Given this list of marker genes NEXMIF, KCNMA1, SYNJ1, SZT2, KCNQ2, GABRA1, AKT3, PCDH19, ITPA, PDE2A, SLC12A5, SCN1A, SCN8A, KCNT1, PDSS2, NDUFA8, POLG, SON, NARS2, KCTD7, GNB1 (G protein subunit beta 1), CILK1, KCNC2, GABBR2, TBC1D20, ODC1, FGF12, BSCL2, STRADA, LMNB2, KIF11, TSC2, COQ2, SLC2A1, ASAH1, TBC1D24, AP3B2, TRAPPC2L, GRIN2A, ADORA2A, TBCK, RHOBTB2, ALDH5A1, GABRA5, GOSR2, KCNH5 (NCBI Gene Id 27133), COG8, SATB1, CTSD, SMARCAL1 (NCBI Gene Id 50485), EHMT1, SMARCA2, EEF1A2 (NCBI Gene Id 6669), DNM1L, FOXG1, PARS2, NHLRC1, GRIN2D, EPM2A, AGO1, CACNA2D1, CACNA1B (NCBI Gene Id 774), TRAK1, NFU1, CNKSR2, SCN1B, PUM1, ACTL6B, CDKN1A, CACNA1E, UNC93B1, CLTC, TSC1, DIS3L2, ARV1, ATP1A1, ALDH4A1, TRAF3, AMACR, PGM2L1, ATP6V0A2, GABRA2, ATP5PO, TEFM, KCNA2, TICAM1 (TIR domain containing adaptor molecule 1), NDUFA6, GABRB2, DHDDS, PPP3CA, PSAP, CDKN1B, FZR1, ATP1A2, TWNK, IQSEC1, ST3GAL5, SYNGAP1, DHCR24, VARS1, BRAT1, PACS2, PIGS (NCBI Gene Id 94005), CACNB4 (NCBI Gene Id 785), CLN6, BCL10, FBXO28, SLC1A2, GRIA4, JRK, KCNQ3, SVBP, COX10, TBK1, VAMP2, QARS1, GPAA1, ARX, CELF2, IFNG, FGF13, AARS1, CDKN2B, GABRD, STXBP1 (NCBI Gene Id 6812), ADGRV1, FIG4, ATP6V1A, GLYCTK, CLCN2, ATXN10, NECAP1, GRIA3, WDR4, SCN9A, YWHAG, CYFIP2, SLC32A1, FH (fumarate hydratase), RNU4ATAC, CRELD1, VPS51, MRM2, ATP1A3, SLC1A3, CACNA1A, PRRT2, GRM7, UBA5, ECE1, SCN3A, MECP2, TLR3, GRIN2B, CDK19, CCDC88A, SLC19A3, GET4, PRODH, KCNB1, PET100, RRM2B, DALRD3, AQP4, CARS2 (cysteinyl-tRNA synthetase 2, mitochondrial), CDKN2C (cyclin dependent kinase inhibitor 2C), PIGA, CAD, COQ8A, MICU1, DNM1, HNRNPU, CHD2, GRIN1, ABCC8, UCP2, CNTNAP2, DTYMK, EFHC1, DEPDC5, HCCS, HCN1, SCN2A, UQCC2, CARS1, PEX5, DEAF1, SLC38A3, SLC25A12, STX1B, PLPBP, ALDH7A1, PNPO (NCBI Gene Id 55163), TANGO2, COX7B, MTOR, NTRK2, NUS1 (NCBI Gene Id 116150), KCNJ11, MAST3, TIMM50, GABRG2, WWOX, MEN1, UPB1, NDUFB11, SLC13A5, PIK3CA, here is a description of the gene set: studied in species Homo sapiens Status epilepticus Status epilepticus is a type of prolonged seizure resulting either from the failure of the mechanisms responsible for seizure termination or from the initiation of mechanisms which lead to abnormally prolonged seizures (after time point t1). It is a condition that can have long-term consequences (after time point t2), including neuronal death, neuronal injury, and alteration of neuronal networks, depending on the type and duration of seizures. Human Gene Set: HP_STATUS_EPILEPTICUS